Given this list of marker genes ARK2C, FGGY, THEM6, GUCY1A1, SEZ6L2, CSRNP2, DRC3, IFT25, TACC2, KCNH2, RAPGEF4, CNP, ARRB2, CCDC107, GALNT10, AGK, SAMD8, FGFBP3, PRKCZ, LRRC75B, RASL11B, TRIM13, TXNRD3, GUCD1, NUDT6, AQP9, PI4K2B, DNTT, PAQR8, RAD52, ZNF579, TMEM31, ZFP2, DCBLD2, TTL, CA11, ETS2, GLT8D2, ORAI2, BRDT, GGT5, MMUT, TTYH3, VIPR1, POLR1A, FCGRT, SLC17A9, TMEM64, CHRNB2, PLEKHA7, CDK11B, AP1G1, AIRN, SLC30A7, MAPKBP1, ATRN, UST, NOD1, SNHG7, TMEM41A, PEMT, SLC35B3, PANK3, RBMS1, CLIC5, GOLGB1, RBM4B, PAXX, AQR, PCED1B, ZDHHC9, SPATA2L, CLDN10, ZNF629, TAFA3, TRIB3, ADCY6, IRGM, QTRT1, ARHGEF33 (NCBI Gene Id 100271715), TREML2, ATG4C, TCP10L, RAB3IP, GPS2, GPCPD1, SETX, CD226 (NCBI Gene Id 10666), LCA5, HSD17B8, ARL4C, CLCN2, PLP1, ARHGEF1, TBC1D16, BRME1, MMP11, DENND2C, TET1 (NCBI Gene Id 80312), CA2, RASA3, HOXA1, PRRG1, CACNB1, DNAJC15, ZFC3H1, EPB41L1, SRSF2, HCFC2, SNHG6, ZBTB11-AS1, CISH, DRC1, CD6, SUOX, SMARCA2, EFR3A, IL4R, PIP5K1B, AP3S2, IL11RA (NCBI Gene Id 3590), ARHGAP15, PHYHD1, SMUG1, SH3YL1, CNKSR3, RPRD1A, AS3MT, PTGIR, ADGRG3, UNC5CL, PADI1, PYROXD2, PARP6, CUEDC2, CRIPTO, EXD2, FAAP100, GGT1, PNPLA7, SMURF1, ABL2, SLC23A3, RGS11, NIN, ME2, TMEM71, LACTB2, DGKA, MAN1A1, STX1A, RDH5, ARMC7, EXPH5, AFMID, MGST3, MTG1, ITGA6, OVGP1, ADPGK, WDR4, IL2RA, MOB3C, DMBT1, ZDHHC15, RMND1, PPM1L, PPM1H, EP400, BRMS1L, DENND4A, ARID1A, RASGRP1, ZBTB34, UAP1, REV1, GFOD2, LATS1, RCN3 (reticulocalbin 3), SLC39A3, ALDH2, LFNG, IMPDH1, FNBP1L, CCR9, KICS2, GABRR2, OTULINL, FRMD6, ZNF865, HID1, SRSF12, DNAAF11, SLC44A2, SF3B1, RSRP1, SFXN3, ERAL1, HEATR5A, WNT5B (NCBI Gene Id 84728), here is a description of the gene set: species: Homo sapiens from publication Nishikawa Y, Hikida M, Magari M, Kanayama N, Mori M, Kitamura H, Kurosaki T, Ohmori H (PMID 17015706) Human Gene Set: GSE4535_BM_DERIVED_DC_VS_FOLLICULAR_DC_DN expression profiles of FDC and BMDC are compared Genes down-regulated in dendritic cells: bone marrow-derived versus follicular.